Given this list of marker genes FGFR2, LBX1, TOP2B, ZNF282, E2F3, HMBOX1, ATP1B3, PLXNA4, here is a description of the gene set: from publication Chen Y, Wang X (PMID 31504780) Genes predicted to be targets of miRBase v22 microRNA hsa-miR-3177-3p in miRDB v6.0 with MirTarget v4 prediction scores > 80 (high confidence targets). Human Gene Set: MIR3177_3P studied in species Homo sapiens